The following is a description of a gene set: Xenobiotics that contain either a carboxylic group or an aromatic hydroxylamine group are possible substrates for amino acid conjugation. Xenobiotics with a <i>carboxylic group</i> conjugate with an <i>amino group</i> of amino acids such as glycine, taurine and glutamine. The <i>hydroxylamine group</i> conjugates with the <i>carboxylic group</i> of amino acids such as proline and serine. The amino acid is first activated by an aminoacyl-tRNA-synthetase which then reacts with the hydroxylamine group to form a reactive N-ester. N-esters can degrade to form electrophilic nitrenium (R-N<sup>+</sup>-R') and carbonium (R-C<sup>+</sup>H<sub>2</sub>) ions. The pyrolysis product of tryptophan, an N-hydroxy intermediate, can potentially form these reactive electrophilic ions. Reactome Pathway: Amino Acid conjugation part of: Phase II - Conjugation of compounds studied in species Homo sapiens, and this is the list of marker genes: ACSM2A, GLYAT, GLYATL3, GLYATL2, ACSM5, ACSM1, ACSM2B, GLYATL1, ACSM4